Given this list of marker genes PTHLH, CXCL14, PTGER2, ENC1, PROM1, C16orf89, MCTP2, WIF1, MT1E, PLPPR4, KCNK17, SYT1, SLFN12L, C1QTNF5, TPST2, STC1, ADAMTSL2, PRAG1, VSNL1, CTXND1, SNED1, ETV5, DACH2, IGSF1 (immunoglobulin superfamily member 1), RGN, FAM118A (NCBI Gene Id 55007), LINC00839 (long intergenic non-protein coding RNA 839), SLC26A2, SAMD5, here is a description of the gene set: studied in species Homo sapiens Myofibro 3 Human Gene Set: HE_LIM_SUN_FETAL_LUNG_C0_MYOFIBROBLAST_3_CELL from publication He P, Lim K, Sun D, Pett JP, Jeng Q, Polanski K, Dong Z, Bolt L, Richardson L, Mamanova L, Dabrowska M, Wilbrey-Clark A, Madissoon E, Tuong ZK, Dann E, Suo C, Goh I, Yoshida M, Nikolić MZ, Janes SM, He X, Barker RA, Teichmann SA, Marioni JC, Meyer KB, Rawlins EL (PMID 36493756)